The following is a description of a gene set: The leaflet the apical region of the plasma membrane that faces away from the cytoplasm and any proteins embedded or anchored in it or attached to its surface. Mouse Gene Set: GOCC_EXTERNAL_SIDE_OF_APICAL_PLASMA_MEMBRANE species: Mus musculus, and this is the list of marker genes: Lct, Abcc4, Abcb1b, Slc38a1, Abcg2, Slc7a5